The following is a description of a gene set: Mouse Gene Set: GOBP_RAL_PROTEIN_SIGNAL_TRANSDUCTION studied in species Mus musculus An intracellular signaling cassette in which a small monomeric GTPase of the RaI subfamily relays a signal., and this is the list of marker genes: Ralgapb, Ralgps1, Ralgapa2, Nkiras1, Rgl2, Nkiras2